Given this list of marker genes FZR1, UBE2E1, ANAPC4, ANAPC5, ANAPC2, ANAPC1, ANAPC16, CDC14A, ANAPC15 (NCBI Gene Id 25906), UBE2S, ANAPC11, UBE2D1, CDC26, ANAPC10, ANAPC7, CDC23, CDC16, CDC20, CDC27, UBE2C, here is a description of the gene set: Reactome Pathway: Conversion from APC/C:Cdc20 to APC/C:Cdh1 in late anaphase The activity of the APC/C must be appropriately regulated during the cell cycle to ensure the timely degradation of its substrates. Of particular importance is the conversion from APC/C:Cdc20 to APC/C:Cdh1 in late anaphase. Phosphorylation of both the APC/C complex and Cdh1 regulate this conversion. During mitosis, several APC/C subunits are phosphorylated increasing the activity of APC/C:Cdc20. However, phosphorylation of Cdh1 by mitotic Cyclin:Cdk complexes prevents it from activating the APC/C. Dephosphorylation of Cdh1 in late anaphase by Cdc14a results in the activation of APC/C:Cdh1. species: Homo sapiens part of: APC/C-mediated degradation of cell cycle proteins